The following is a description of a gene set: The regulated release of follicle-stimulating hormone, a gonadotropic glycoprotein hormone secreted by the anterior pituitary. studied in species Mus musculus Mouse Gene Set: GOBP_FOLLICLE_STIMULATING_HORMONE_SECRETION, and this is the list of marker genes: Tbx3, Inha, Crhr2, Inhba, Foxl2, Cga, Ucn2, Lep, Smad4, Acvr2a, Inhbb